Given this list of marker genes CHML, LRRN4, KCNAB3, LPAR3, PAFAH2, RAB39A, MAOB, HEMGN, ORM2, FLVCR1, TRIM65, KRTAP19-5, SPAG1, CFP, ROM1, SPARCL1, P4HA3, DHRS13, MAGEB16, PTPN6, DLEU7, DKC1, ZSCAN10, STRAP, OSBPL5, DCAKD, RAB33A, MIA2, PRAMEF2, EFCAB14, CFAP96, IGFBP7, KBTBD4, CELA2A, ANP32B, HMGCR, MAN1A2, NUP43, HAUS6, LAYN, PLAUR, SCCPDH, STK31, SCN2A, PLEKHA2, MDH1 (malate dehydrogenase 1), IARS1, TLE6, PLEKHF1, NPL, ANKRD37, KRT79, ARHGAP29, NGLY1, TFAP2E, NCAPG2, METTL9, HMGCS1, SEMA5A, ENOX2, LACTB2, SHROOM2, HELLS, LMOD1, DSCC1, DUBR, C1QTNF7, SLC6A12, IFT70A, C17orf50, ALS2CL, FBXL8, UBE3D, GHSR, TMEM47, HRH2, HK2, TOP2B, WDR5B, MCM3, CKAP4, ME2, AK4, KPNA2, CAPS2 (NCBI Gene Id 84698), GRK1, ATP8B4, DACH2, COL27A1, BRF2, ECT2, ASZ1, LRRC23, CEP55, EFCAB11, CDCA4, ZNF324B, AKR1D1 (aldo-keto reductase family 1 member D1), ANKRD22, AQP6, MLF1, ALMS1, LIN9, BMP2K, LONRF3, RGS9BP, MBOAT1, MYF6, MAD1L1, PDE3B, RECQL4, ABCB7, RNPS1, C16orf78, PROP1, FAM221A, ALG6, C1GALT1, EMB, CYP4A22, LYPD6B, KCNE1 (potassium voltage-gated channel subfamily E regulatory subunit 1), BUB3, PDE12, SF1, HHAT, MCTP1, CXCR6, TRAT1, PLSCR4, KRTAP20-2, TFB1M, CENPC, DRAXIN, TEX36, ILF2, SUGCT, CRYGB, LCE1A, COL4A3, IL17D, GATA4, OIP5, DACH1, ENDOV, MCM6, SSNA1 (NCBI Gene Id 8636), ATF6, GJA1, CHGA, MTIF2, PGAM1, LIMS4, TECTA, ADD3, ATP11C, SUSD2, QRFPR, GGT1, TRPA1, UBA6, RP1, LRR1 (NCBI Gene Id 122769), FAM217B, INPP5B, C1orf35, PFKP, ZBTB39, GGACT, TRPM1, FAM20A, DOCK4, ESCO2, OXSR1, FAM151B, ABHD1, SLC25A25, LACC1, SNRPB, KIRREL3, NANP, GPATCH11, SAP30, CIMIP2C, RB1, SVIL, PAPPA, SLC2A1, ZNF367, POLE2, ITGAM, CYSLTR1, GPKOW, PRELID1, SEMA3G, VARS1, CCKAR, SLC25A10, DNAH12, here is a description of the gene set: The transcription factor Foxp3 is usually considered the master regulator for the CD4+CD25+ Human Gene Set: GSE7460_CTRL_VS_FOXP3_OVEREXPR_TCONV_1_UP from publication Hill JA, Feuerer M, Tash K, Haxhinasto S, Perez J, Melamed R, Mathis D, Benoist C (PMID 18024188) species: Homo sapiens Genes up-regulated in comparison of CTRLrv versus FOXP3rv (see Fig. 1 for details).